Given this list of marker genes Cnp, Msn, Actn4, Klhl41, Myoz1, Ldb3, Raf1, Rab25, Pla2g6, Arrb1, F2rl1, Capn2, Mapk1, Mapk3, here is a description of the gene set: studied in species Mus musculus A temporary protrusion or retractile process of a cell, associated with flowing movements of the protoplasm, and serving for locomotion and feeding. Mouse Gene Set: GOCC_PSEUDOPODIUM